Given this list of marker genes Gramd4, Atxn10, Mirlet7b, Gm22818 (NCBI Gene Id 115488607), AU022754, Lncppara, Phf21b, Mir1249 (microRNA 1249), Upk3a, Parvg, Gtse1, Efcab6, Pnpla3, Trmu, Cdpf1, Tbc1d22a, Pnpla5, 7530416G11Rik, Arhgap8, Gm5214, Gm4217, 4930513L16Rik, Wnt7b, Gm4825, Gm6847, Cerk, Gm20556 (predicted gene, 20556), Gm10923, Gm34095, Rpl31-ps22, Fam118a, Samm50, Mirlet7c-2, Prr5, A930001M01Rik, Smc1b, Gm33432, Ribc2, Celsr1, Gm15569 (NCBI Gene Id 102638208), Rtl6, Gm20369, Gm23517, Sult4a1, Gm19277, Gm46526, Ppara, Shisal1, Gm15722, Pkdrej, 5031439G07Rik, Ttc38, Fbln1, Gm22890, Nup50, Mir6392, Parvb, here is a description of the gene set: species: Mus musculus Mouse Gene Set: chr15E2